The following is a description of a gene set: studied in species Homo sapiens Genes predicted to be targets of miRBase v22 microRNA hsa-miR-6759-5p in miRDB v6.0 with MirTarget v4 prediction scores > 80 (high confidence targets). from publication Chen Y, Wang X (PMID 31504780) Human Gene Set: MIR6759_5P, and this is the list of marker genes: JMJD8, PRMT8, CERS6, PAXBP1, THAP10, AMMECR1L, TYRO3, GLYAT, ELAPOR1, CLPX, HDAC4, GJA3, EPHA8, SGCD, SLCO3A1, COL5A2, ETS2, UBE2D2, NCBP3, FA2H, ZNF37A, NKIRAS2, OPRPN, SLC9A6, MEX3A, TRAPPC9, MMP16 (NCBI Gene Id 84257), MTSS1 (NCBI Gene Id 9788), ZNF705D, KCNK9, TIFAB, PRKCI, PPFIA1, CAMK1D, SFRP4, PHF6, FGFR1, PGBD2, LGR5, ZNF705EP, ASPH, EDNRA, NEXMIF, LASP1, C1orf141, CNFN, VWF, DERL1, SEMA6A, SEPTIN3, KHDRBS1, ZNF705A, RBM12B, DLG1, SRR, RERE, TMEM108, FGG, FOXI2, PLXNA2, NFKBID, SAA2, CD37, SLC7A1, NEK7, NCAPH